The following is a description of a gene set: studied in species Homo sapiens Human Gene Set: REACTOME_NONSENSE_MEDIATED_DECAY_NMD Nonsense-Mediated Decay (NMD), and this is the list of marker genes: SMG7, RPS14, RPS3A, RPL5, SMG9, RPL14, RPL36, RPL18, CASC3, RPS6, RPS25, SMG5, RPL31, DCP1A, RPL21 (ribosomal protein L21), PNRC2, RPS5, RPS26, RPL8, RPL9, RPL23A (NCBI Gene Id 6147), RPL28, NCBP2, RPL13, RPS17, RPL26, RPS16, GSPT1 (NCBI Gene Id 2935), PABPC1, RPS8, UBA52, RPL35A, RPL22, RPL10, RPS11, RBM8A, RPS19, RPL3L, RPS15, RPS12, RPS2, RPL7, RPS28, RPS21, RPS4X, RPL34, MAGOH (NCBI Gene Id 4116), RNPS1, RPSA, UPF1, RPL27A, RPL29, RPS7, RPS13, RPL39L, MAGOHB, RPS10 (ribosomal protein S10), RPS4Y1, RPL37, RPL36A, RPLP0, RPS4Y2, PPP2CA (protein phosphatase 2 catalytic subunit alpha), SMG6, FAU, RPL15, UPF3A, UPF3B, RPS27A, RPL19, RPS23, RPL32 (ribosomal protein L32), UPF2, RPS24, SMG8, RPL10A, RPL30 (NCBI Gene Id 6156), SMG1, RPL17, RPL11, RPL27, RPL24, RPL6, RPLP1, RPLP2, EIF4G1, ETF1, PPP2R2A, RPS15A, RPS29, RPS9, RPL4, GSPT2, RPL35, RPL10L, RPL38, RPS27L, RPL22L1, RPL23, RPL26L1, RPL37A (NCBI Gene Id 6168), RPS3, RPL41 (NCBI Gene Id 6171), EIF4A3, NCBP1, PPP2R1A, RPS27, RPL39, RPL3, RPL12, RPL18A, RPL7A, RPL13A, RPS18, RPS20, RPL36AL